The following is a description of a gene set: studied in species Mus musculus Mouse Gene Set: GOCC_TRIGLYCERIDE_RICH_PLASMA_LIPOPROTEIN_PARTICLE A plasma lipoprotein particle that has a hydrophobic core enriched in triglycerides surrounded by an amphipathic monolayer of phospholipids, cholesterol and apolipoproteins. Triglyceride-rich lipoprotein particles transport lipids, which are non-covalently associated with the particles, in the blood., and this is the list of marker genes: Apoe, Lpl, Apom, Lsr, Apoa2, Apoc1, Apol11b, Apoc4, Apoa5, Apoc3, Vldlr, Apoc2, Apol8, Apoa4 (NCBI Gene Id 11808), Pcyox1, App, Apoh, Apobr, Apol9a, Apol9b, Apob, Apoa1, Apol10b, Apol10a, Selenos, Apol11a, Apoc2l